Given this list of marker genes RNF141, HOXA13, BHLHE40, ITGB1, NDUFAF7, MPV17L2, COBLL1, GTF2H5, UCK2, HMGN3, TTC9C, TRAK1, MAPK1, ATP5MF, CD83, MYO1B, LRRC75A, EBI3, GNG12, CMC2, NPAS2 (NCBI Gene Id 84195), CLTB, MAGED1, HK2, PELP1, SLC17A6, CNTLN, TMEM237, MID1IP1, SFMBT1, PRKRIP1, LONRF1, DLL3, TRAPPC2B, AK7, COQ3, FKBP1A, TMEM41B, PHB1, YES1 (YES proto-oncogene 1, Src family tyrosine kinase), NUDT5 (nudix hydrolase 5), DYNLL2 (dynein light chain LC8-type 2), C11orf24, MARCKSL1 (MARCKS like 1), UBXN11, PSMG4, PLPP1, TAF11, NDUFB4, SRD5A1, SNRNP25, GINS3, DMAC1, NIF3L1, SMDT1 (NCBI Gene Id 91689), LURAP1, ENDOD1, ARR3, FAM162A, RAB11FIP4, SNX27, NDUFAB1, CACNA1S, ATL2, UBE2L3, NEFH (NCBI Gene Id 4744), KLF7, C11orf58, SAMD14, NUCB2, MTHFD2, VWA7, NDUFA11, CHCHD6, NDUFS8, ITSN1, TBCB, TMEM209, TSN, AVEN, ST6GALNAC6, PHLDB1 (pleckstrin homology like domain family B member 1), POLE3, KRT36, NSMCE2, BRME1, NTHL1, UQCR10, HMCES, SUPT3H, PSMA7, DCBLD2, FOCAD, SEC61G, SLC35B2, TFRC, HIVEP3, PTGIR, CISD1, ALDOC (NCBI Gene Id 230), ERI3, HACD2, HNRNPA3, MYBL1, UBE2QL1, NDUFS4, PKM, GLOD4, CYB561, SEMA4C, ACYP2, UBE2M, SEC14L5, SDR39U1, PGAM1, IRAK1BP1, SNF8, FANCC, PDCD1LG2, RBBP7, CISD3, PXMP4, PECR, UBE2K, LMNB2, TMEM107 (transmembrane protein 107), LYRM2 (LYR motif containing 2), COLCA1, EEPD1, CHML, RNF121, CHCHD10 (coiled-coil-helix-coiled-coil-helix domain containing 10), MZT2B, MFSD13A, VAX2, MCEE, PPFIBP1, PSMD1, NME6, VAMP5, DHRS1, ANXA4, NRGN (NCBI Gene Id 4900), SF3B5, PDE6A, NDUFC2, UQCRQ, MRPL48, MAPKAPK2, STARD3NL, MEGF9, ALAD, PXMP2, HMGB3, ROCK2, CDC42EP4, TIMM8B, ATL3, IPMK, RBM15B, ITGB6, SLC9A5, ARFGEF3, LIG1, ENO1, TPD52, MIF, ZBTB3, ARL2, ZNHIT1, CA11 (NCBI Gene Id 770), CRYBG3, FAF1, BRMS1L, TMEM256, CAMK2N2, SEPTIN8, NDUFB2 (NCBI Gene Id 4708), SSX2IP, UPK1A, NUP133, GALK1, MRPL14 (NCBI Gene Id 64928), IMMP2L, STRN, COX6B2, PGK1, TPI1, NAA38, TG, PDXP, SENP1, INSIG1, DNAJC15, ZNF414, PPP1R11, SPTSSA, IMPA2, PIH1D2, PSMG1, here is a description of the gene set: from publication Gallina G, Dolcetti L, Serafini P, De Santo C, Marigo I, Colombo MP, Basso G, Brombacher F, Borrello I, Zanovello P, Bicciato S, Bronte V (PMID 17016559) Genes up-regulated in ITGAM+ cells from spleens of tumor bearing mice: processed immediately versus those incubated for 24h in complete medium. species: Homo sapiens Active suppression of tumor-specific T lymphocytes can limit the immune-surveillance and immunotherapy efficacy. While tumor-recruited CD11b+ myeloid cells are known mediators of tumor-associated immune dysfunction, the true nature of these suppressive cells and the fine biochemical pathways governing their immunosuppressive activity remain elusive. Here we describe a population of circulating CD11b+/IL-4Rα+, inflammatory-type monocytes that is elicited by growing tumors and activated by IFN-γ released from T lymphocytes. CD11b+/IL-4Rα+ cells produce IL-13 and IFN-γ and integrate the downstream signals of these cytokines to trigger the molecular pathways suppressing antigen-activated CD8+ T lymphocytes. Analogous immunosuppressive circuits are active in CD11b+ cells present within the tumor microenvironment. These suppressor cells challenge the current idea that tumor-conditioned immunosuppressive monocytes/macrophages are alternatively activated. Moreover, our data show how the inflammatory response elicited by tumors has detrimental effects on the adaptive immune system and suggest novel approaches for the treatment of tumorinduced immune dysfunctions. Human Gene Set: GSE5455_EX_VIVO_VS_POST_24H_INCUBATION_MONOCYTES_FROM_TUMOR_BEARING_MOUSE_UP